Given this list of marker genes SLC7A10, SLC36A1, SLC3A2, SLC16A10, SLC66A1 (NCBI Gene Id 54896), SLC25A12, SLC25A18, UCP2, SLC25A29, SERINC5, SLC7A3, SLC7A8, SLC17A6, SLC7A7, SLC1A2, SLC7A1, SLC7A11, SLC7A9, SLC6A20, SLC7A2, SLC25A22, SLC15A4, SLC25A2, SLC1A5, SLC1A1, SLC36A3, SLC43A1, SLC66A1LP, SLC38A7, SLC1A3, SLC22A2, SLC7A13, SLC17A8, SLC1A4, SFXN3, SLC38A5, SLC38A11, SLC38A2, SERINC3, SLC6A7, SLC7A6, SLC7A5, SLC1A7, SLC38A6, SLC17A7, SLC43A2, SLC1A6, CTNS (NCBI Gene Id 1497, cystinosin, lysosomal cystine transporter), SLC3A1, SLC25A15, SLC38A9, SLC38A8, SLC36A2, SLC38A4, SLC47A1, SLC36A4, SLC25A26, SLC38A1, SFXN1, SLC38A10, SLC38A3 (solute carrier family 38 member 3), SLC25A13, here is a description of the gene set: studied in species Homo sapiens Human Gene Set: GOMF_L_AMINO_ACID_TRANSMEMBRANE_TRANSPORTER_ACTIVITY Enables the transfer of an L-amino acid from one side of a membrane to the other. L-amino acids are the L-enantiomers of amino acids.